Given this list of marker genes MLF2, LRP2, CMTR2, RBMXL2, H4C3, FOXN3, LCP2, NCKAP5, PTCHD4, SPDEF, RNF128, USP34, JUNB, H3-3B, PAX9, DENND1B, LYSMD2, PART1, NR4A1, POU3F2, MYH8 (NCBI Gene Id 4626), SLC25A25, LINC01597, ARX, IER5L, MANEAL, SOX5, TP63 (NCBI Gene Id 8860), DMD, ZMYND8, ERG, CDH9, COMMD3, B3GLCT, NCDN, DDX17, COMMD10, MYCT1, GPR12, CEP120 (NCBI Gene Id 153241), NRXN3, ZIC5, LRFN5, HOXA6, ENSG00000291228, RP1L1, ZEB2, GOLGA1, MID1, BMP5, HOXD3, SLITRK2, PHOX2B, UHRF2, KCNN3, NOTCH1, TLK1, CREB5, GOLPH3L, RAPH1, POU3F4, RNF111, ZNF710, SLC35C2, LMNA, SRSF6, ZBTB18, CNOT7, RNF17, SIX3, DSG4, TRIM24, COMMD6, E2F3, DCUN1D1, HOXB2, BEST3, BAIAP2L1, CALHM5, SLITRK1, PTN, AP3M1, PABIR1, IGFL3, DIP2B, MIR137HG, PCSK2, PAX6, NRAS, SPTB, ELAVL2, LARP4, TOB1, EMCN, CACNA1C, ARMC1, DLC1, DHX30, GTF2B, GSK3B, HS6ST2, LOXL2, NPHP4, CRACDL, ZBTB9, FOXO4, MIR9-1HG, BHLHE22, MYF6, SALL1, TUG1, LMO3, TACSTD2, CDK11B, COA3, ARHGAP17, NRG1, CWC15, EXOC6, HTN1, TFAP2D, G6PC1, HOXC4, IKZF4, MYT1, ZNF512, ZNF423, CDK11A, PROX1, BCL11A, TCF12, TSHZ3, BEND4, CNTNAP4, RS1, TBR1, KCNMA1, JADE2, GADL1, ZIC1, NR2F1, MYH4 (myosin heavy chain 4), IFNG, CYP26C1, SLITRK5, ELMO3, EYA1, CCIN, ZNF521, KREMEN1, ATP2A2, SH3RF1, CLDND1 (claudin domain containing 1), LRRTM1, DAB1, DENND6A, DMRTB1, GPR85, THRA (thyroid hormone receptor alpha), EGR2, NAP1L5, OTUD7B, PROCR, NOG, ADAM11, ASB4, LINC00671, FDX2, ASCL4, HOXC6, VPS37A, CASC3, KRTAP11-1, HP1BP3, KIT, MYH2, HOXA3, SLITRK3, SMAD5, RIOK3, ENTHD1, NNAT, FBXW4, C12orf50, SULT2A1, ADAMTS17 (NCBI Gene Id 170691), PTH1R, RAB3C, TPM1, PDZRN4, CNTD1, ALX1, PCDHA9, PSMA1, TMEM242, DNASE2B, NEDD4, UQCRB, TRIB2, WNT7A, CPA4 (NCBI Gene Id 51200), OTP, ADK, MBNL1, KERA, LMO1, ARAP2, HOXA2, DLG2, CADM1, LHX5, FOXP2, DCDC1, GRM8, KDM4D, DCAF11, LUC7L3, XIAP, RLIM, WT1-AS, DENND4A, GEMIN2, ZFPM2, POU2F1, GIGYF2, EFEMP1, ZIC4, HABP2, CHM, UBXN10, SUPT3H, ADGRL1, CHRM1, STC1, PNMA1, SIX1, ADGRF1, SH3KBP1, HOXD4, here is a description of the gene set: Human Gene Set: NKX3A_01 studied in species Homo sapiens Genes having at least one occurrence of the motif NWATAAGTATWT in the regions spanning 4 kb centered on their transcription starting sites. This matches the NKX3-1 transcription factor binding site V$NKX3A_01 (v7.4 TRANSFAC).